Given this list of marker genes CACNG4, MGA, NUP107, PLAGL1, WWC3, AP2A1, RGS5, ZNF266, CRYZL1, NEUROD6, NCS1, EVI2B, COL6A1, PLEKHA1 (NCBI Gene Id 59338), AHNAK, ZNF185, COA8, PTGIS, IGHM, IGLJ3, NUDT22, INTS11, here is a description of the gene set: Genes in the cancer module 156. Human Gene Set: MODULE_156 species: Homo sapiens